The following is a description of a gene set: species: Mus musculus Mouse Gene Set: REACTOME_REGULATION_OF_RUNX1_EXPRESSION_AND_ACTIVITY Regulation of RUNX1 Expression and Activity, and this is the list of marker genes: Ccnd2, Ccnd1, Ccnd3, Cbfb, Pml, Cdk6, Ptpn11